The following is a description of a gene set: Genes having at least one occurrence of the motif NNGTNRCNWRGYAACNN in the regions spanning 4 kb centered on their transcription starting sites. This matches the RFX1 transcription factor binding site V$RFX1_01 (v7.4 TRANSFAC). Human Gene Set: RFX1_01 studied in species Homo sapiens, and this is the list of marker genes: FAM219A, NEDD9, AGBL2 (NCBI Gene Id 79841), HSF1, MTTP (NCBI Gene Id 4547), HECTD1, MECOM, PURA, SOWAHA, CX3CL1, RNF25, APOO, ST13, WHRN, XPNPEP3, RASGEF1A, ASB7, TBX5, NKX2-1, CALB2, TRAF4, HSPG2, SMAD5, SAXO4, LRRC46, WDR17, HAT1, TBC1D16, MED25, SMG6, NECTIN4, GOLPH3L, MRPL10, ORAI3, OVOL2 (ovo like zinc finger 2), TFIP11, SYT16, PIGW, DIO3, NAA60, PRRX1, NAT14, FZD1, TBATA, HEATR4 (HEAT repeat containing 4), SMG1, CTF1, DPAGT1, MYO1C, PAK6, TCF12, RIT2, HOXA10, HDAC9, RRAGA, UBE2U, BRD2, FAM167A, PTDSS2, CDC14A (cell division cycle 14A), DNAH7, CBX8, SIX1, GRIK5, CYTH2, YWHAQ, ZFP36L2, LMO3, SPTAN1, SHC3, ACBD3, PELI3, RPS6KA5, ARL4A, STOML2, ZCCHC8, ENOX1, PDCL2, F2RL1, PRDM4, MANEA, TBPL1, ARFGEF2, COQ8B, ACTG2, DYNLL1, CCDC33, ASXL2, NAB2, PRKN, PITX2, CFAP20DC, EFTUD2, UBB, ADM, MDH1B (NCBI Gene Id 170470), CDIPT, SMC1B, NALF2, NRGN, FIBCD1, FXYD6, PACRG, ZFYVE1, CACNA2D3 (NCBI Gene Id 55799), SOX3, GSK3B, FGR, NLGN2, CNOT10, GABARAPL2, RSPH14, CIBAR2, C2orf15, HMGCS1, TUSC3, RIBC2, JOSD2, ARL13B, MYO19, PCGF1, BOP1, EFNA1, CPXCR1, UBXN10, PTCH1, ZNF385B (zinc finger protein 385B), BCAP31, BTRC, IGF1, AKIRIN1, LINC00649, JADE2, KRTAP11-1, HCAR3, SRR, SELENOF, GJB1, WWOX, CPEB2, HM13, DMD (NCBI Gene Id 548327), KIF17, ARHGAP44, GTF3C4, IDS, GPX1, EFNB3, DUSP4, DNAI1, TPCN1, DYNLRB2, MFN1, GRIA1, MIR137HG (MIR137 host gene), GRM3, SLC8A3, PSMF1, BNC2, PNKD, ZNF646, CCDC126, CFL2, FANCD2OS, SPA17, ARHGAP15, DYDC2, LINS1, EFHC2, PTPRT, ANXA1, SDCBP2, CARS1, NME5, PPOX, GBF1, BRWD3 (bromodomain and WD repeat domain containing 3), GSN, IQCD, CCDC60, MYH8 (myosin heavy chain 8), DHX8, CORO6, IGSF8, FILIP1, PES1, MAGED1, RIBC1, AP1M1, SCN2A, C5orf15, WDR90 (NCBI Gene Id 64488), SFR1, ZRANB1, SIK1, PRICKLE1, CIMIP2A, PDZD4, TSGA10, YIPF5, DNAL4, GDE1, PIGA, SALL2, GALNT14, GPR119, RFC5, MIEF2, B3GALT2, E2F5, C10orf53, PRKCSH, TMEM131L (NCBI Gene Id 23240), MSL2, KCNJ2, CKMT1B, BIK, BDNF, MAP9, BMP6, FUZ, CCP110, KIRREL2, DNAH9, ENKD1, DDX41, DDX17, HS2ST1, CITED2, ABCD1, XRCC1, CIMIP6, PPP2R2B, NCOA5, CXorf58, GGN, SNRPF, CPLANE2, BBS2, TENT5D, STMN4, VEGFA, FASTKD2, TEKT2, CCDC65, TRERF1, SH3GL3, CCDC103, PIK3R4, PLCB3, SWSAP1, NPM1, FAM76A, DRP2, KLHDC10, BCL2L1, PAX6, CEP83, POLR3H (NCBI Gene Id 91605), IFT88, CAPN3, FHIP1B, MDH1, TTC16